Given this list of marker genes Dync1h1, Epx, Nucb1, Ear1, Gata1, Il11ra2, Nucb2, Map4k4, Vamp8 (vesicle-associated membrane protein 8), Hip1r, E2f1, Gata2, Prg2, Prg3, Nfkb1, Hdac2 (histone deacetylase 2), Ikbkb, Dok2, Alox15 (arachidonate 15-lipoxygenase), Hdgf, Etf1, Rps12, Set, Polr2l (NCBI Gene Id 66491), Il3ra, Camp, Psmc5 (protease (prosome, macropain) 26S subunit, ATPase 5), Gtf3c1, Nelfe, Ctsh, Gorasp2, Tspan32, Serpinb2, Cd63, Ly6c2, Lyl1, Vcam1, Ptpn2 (NCBI Gene Id 19255), Tacstd2, Rbbp4, Ctdsp2, Rpl41, Stx3, here is a description of the gene set: species: Mus musculus Interleukin-5 (IL-5) is a hematopoietic differentiation factor that promotes the development of mature eosinophils from progenitors in bone marrow. We present a multifactorial microarray study documenting the transcriptional events in bone marrow of wild-type and IL-5-deficient mice at baseline and in response to infection with Schistosoma mansoni. The microarray data were analyzed by a 4-way subtractive algorithm that eliminated confounding non-IL-5-related sequelae of schistosome infection as well as alterations in gene expression among uninfected mice. Among the most prominent findings, we observed 7- to 40-fold increased expression of transcripts encoding the classic eosinophil granule proteins (eosinophil peroxidase, major basic protein, the ribonucleases) together with arachidonate-15-lipoxygenase and protease inhibitor plasminogen activator inhibitor 2 (PAI-2), in the IL-5-producing, infected wild-type mice only. This was accompanied by increased transcription of genes involved in secretory protein biosynthesis and granule-vesicle formation. Interestingly, we did not detect increased expression of genes encoding eosinophil-related chemokine receptors (CCR1, CCR3) or members of the GATA or CCAAT/enhancer binding protein (C/EBP) transcription factor families. These data suggest that the IL-5-responsive progenitors in the mouse bone marrow are already significantly committed to the eosinophil lineage and that IL-5 promotes differentiation of these committed progenitors into cells with recognizable and characteristic cytoplasmic granules and granule proteins. Mouse Gene Set: BYSTROEM_CORRELATED_WITH_IL5_UP Genes whose expression in bone marrow samples correlated directly with increased levels of serum IL5. from publication Byström J, Wynn TA, Domachowske JB, Rosenberg HF (PMID 14525773)